The following is a description of a gene set: Short distal phalanx of the 5th finger studied in species Homo sapiens Hypoplastic/small distal phalanx of the fifth finger. Human Gene Set: HP_SHORT_DISTAL_PHALANX_OF_THE_5TH_FINGER, and this is the list of marker genes: IGF2, HNRNPR, ARID1B, SMARCB1, COL2A1, ERI1